The following is a description of a gene set: Binding to glycine, aminoethanoic acid. Mouse Gene Set: GOMF_GLYCINE_BINDING species: Mus musculus, and this is the list of marker genes: Gldc, Grin3a, Grin2b, Glrb, Gss, Grin1, Glra1, Cep104, Glra4, Glra3, Glra2 (glycine receptor, alpha 2 subunit), Srr, Gnmt, Grin3b